Given this list of marker genes PLA2G2E, MIF (NCBI Gene Id 4282), ACSL1, CPT1B, SPX, DRD4, PLA2G4A, NTSR1 (neurotensin receptor 1), PPARG, SLC25A20, ACSL5, PLA2G2A, PLA2G3, CD36, TMEM135, APOE, SLC2A1, THBS1, AKT2, MFSD2A, PLA2G12B, ABCD2, UCP2, SYK, AKT1, CPT1A, ABCD3, SLC27A4, PLA2G2D, ACSL3, NMUR2, FABP2, DRD2, PLIN2, NMB, FABP3, FABP5, IRS2, OC90, PLA2G4F, BDKRB2, PLA2G1B, ABCD1, PNPLA8, AVPR1B, SLC27A5, ABCD4, EPRS1, ACE, PLA2G12A, FABP4, RPS6KB1, SLC27A2 (NCBI Gene Id 8523), ANXA1 (annexin A1), PLA2G5, SLC27A6, PLA2G2C, CPT2, PLA2R1, DRD3, PLA2G2F (phospholipase A2 group IIF), PLA2G10, PROCA1, SLC27A1, FABP9, here is a description of the gene set: studied in species Homo sapiens The directed movement of a long-chain fatty acid into, out of or within a cell, or between cells, by means of some agent such as a transporter or pore. A long-chain fatty acid has an aliphatic tail containing 13 to 22 carbons. Human Gene Set: GOBP_LONG_CHAIN_FATTY_ACID_TRANSPORT